The following is a description of a gene set: Catalysis of the transient cleavage and passage of individual DNA strands or double helices through one another, resulting a topological transformation in double-stranded DNA. species: Mus musculus Mouse Gene Set: GOMF_DNA_TOPOISOMERASE_ACTIVITY, and this is the list of marker genes: Top2a, Top1, Top3a, Top3b, Top2b, Spo11, Top6bl, Top1mt